The following is a description of a gene set: PURPOSE: Genomic aberrations and mutational status of the immunoglobulin variable heavy chain (VH) gene have been shown to be among the most important predictors for outcome in patients with B-cell chronic lymphocytic leukemia (B-CLL). In this study, we report on differential gene expression patterns that are characteristic for genetically defined B-CLL subtypes. MATERIALS AND METHODS: One hundred genetically well-characterized B-CLL samples, together with 11 healthy control samples, were analyzed using oligonucleotide arrays, which test for the expression of some 12,000 human genes. RESULTS: Aiming at microarray-based subclassification, class predictors were constructed using sets of differentially expressed genes, which yielded in zero or low misclassification rates. Furthermore, a significant number of the differentially expressed genes clustered in chromosomal regions affected by the respective genomic losses/gains. Deletions affecting chromosome bands 11q22-q23 and 17p13 led to a reduced expression of the corresponding genes, such as ATM and p53, while trisomy 12 resulted in the upregulation of genes mapping to chromosome arm 12q. Using an unsupervised analysis algorithm, expression profiling allowed partitioning into predominantly VH-mutated versus unmutated patient groups; however, association of the expression profile with the VH mutational status could only be detected in male patients. CONCLUSION: The finding that the most significantly differentially expressed genes are located in the corresponding aberrant chromosomal regions indicates that a gene dosage effect may exert a pathogenic role in B-CLL. The significant difference in the partitioning of male and female B-CLL samples suggests that the genomic signature for the VH mutational status might be sex-related. Genes changed in the B cell chronic lymphocytic leukemia (B-CLL) with mutations in the variable immunoglobulin veriable heavy chain (VH) genes. species: Homo sapiens from publication Haslinger C, Schweifer N, Stilgenbauer S, Döhner H, Lichter P, Kraut N, Stratowa C, Abseher R (PMID 15459216) Human Gene Set: HASLINGER_B_CLL_WITH_MUTATED_VH_GENES, and this is the list of marker genes: TLE1, PCDH9, WSB2, KLK2, PCSK7, LPCAT1, LDOC1, NRIP1, TCF7, SLAMF1, COBLL1, SORL1, DMD, ZBTB20 (NCBI Gene Id 26137), P2RX1, LPL, IL10RA, MAL